The following is a description of a gene set: The chemical reactions and pathways resulting in the formation of testosterone, an androgen having 17beta-hydroxy and 3-oxo groups, together with unsaturation at C-4 C-5. studied in species Mus musculus Mouse Gene Set: GOBP_TESTOSTERONE_BIOSYNTHETIC_PROCESS, and this is the list of marker genes: Star, Hsd17b3, Ggcx, Bglap, Hsd17b1, Creb1 (NCBI Gene Id 98624), Cmtm2a, Bglap2, Akr1c18, Srd5a2, Inhba, Gprc6a (NCBI Gene Id 210198), Cyp19a1 (cytochrome P450, family 19, subfamily a, polypeptide 1, NCBI Gene Id 13075), Prkg1, Wnt4 (wingless-type MMTV integration site family, member 4), Dkkl1 (NCBI Gene Id 50722)